Given this list of marker genes IGBP1 (NCBI Gene Id 3476), PRDX1, ZMPSTE24, IL26, NBR1, ARL6IP5, NOD1, KLHDC10, GSTP1, QARS1, MAP2K1, MAPK8IP2, GREM1, INAVA, DUSP10, SEMA4C, PBK, TAOK1, TLR4, STK25, FAS, MID1, MAP2K2, FOXO1, CARD9, TGFB2, TAOK3, MAP3K20, FOXM1, TAOK2, MAPK3, MYC, EIF2AK2, MAPK1, IGFBP6, RIPK2, PDCD10, PAGE4 (NCBI Gene Id 9506), SCIMP, PPIA, NOD2, here is a description of the gene set: species: Homo sapiens Human Gene Set: GOBP_REGULATION_OF_STRESS_ACTIVATED_PROTEIN_KINASE_SIGNALING_CASCADE Any process that modulates the frequency, rate or extent of signaling via a stress-activated protein kinase signaling cascade.